Given this list of marker genes CYP2C8, RELN, HLA-DRA, VNN1, RSRC2, FABP1, CELA1, PPP1R2, ELOVL2, MCM10, INMT, CES3, IGKV5-2, PRLR, HAO2, UBAP2L, LIFR, OAT, ADRB3, SLC1A2, CYP7B1, PIGU, CES1, LIPC, HSD3B2, NR1D1, GSTM5, RETSAT, VEGFB, PAX3, RPAP1, RBM4B, CYP4A22, ACSL1 (acyl-CoA synthetase long chain family member 1, NCBI Gene Id 91249), IGFALS, PDZK1, CA14, KLF2, CTSE, CYP2B6, IGKC, ELAC2, HMGCS2, HP, GAS1, G6PC1, ADCY9, AVPR1A, FBXO21, PPP1R3C, CYP8B1, KLF10 (KLF transcription factor 10), CASP6, SLC22A25, MKLN1, BMPR2, HSD3B1, here is a description of the gene set: from publication Ichiba T, Teshima T, Kuick R, Misek DE, Liu C, Takada Y, Maeda Y, Reddy P, Williams DL, Hanash SM, Ferrara JL (PMID 12663442) Human Gene Set: ICHIBA_GRAFT_VERSUS_HOST_DISEASE_35D_DN Hepatic graft versus host disease (GVHD), day 35: genes down-regulated in allogeneic vs syngeneic bone marrow transplant. species: Mus musculus The liver, skin, and gastrointestinal tract are major target organs of acute graft-versus-host disease (GVHD), the major complication of allogeneic bone marrow transplantation (BMT). In order to gain a better understanding of acute GVHD in the liver, we compared the gene expression profiles of livers after experimental allogeneic and syngeneic BMT using oligonucleotide microarray. At 35 days after allogeneic BMT when hepatic GVHD was histologically evident, genes related to cellular effectors and acute-phase proteins were up-regulated, whereas genes largely related to metabolism and endocrine function were down-regulated. At day 7 after BMT before the development of histologic changes in the liver, interferon gamma (IFN-gamma)-inducible genes, major histocompatibility (MHC) class II molecules, and genes related to leukocyte trafficking had been up-regulated. Immunohistochemistry demonstrated that expression of IFN-gamma protein itself was increased in the spleen but not in hepatic tissue. These results suggest that the increased expression of genes associated with the attraction and activation of donor T cells induced by IFN-gamma early after BMT is important in the initiation of hepatic GVHD in this model and provide new potential molecular targets for early detection and intervention of acute GVHD.